The following is a description of a gene set: species: Mus musculus from publication Mikkelsen TS, Hanna J, Zhang X, Ku M, Wernig M, Schorderet P, Bernstein BE, Jaenisch R, Lander ES, Meissner A (PMID 18509334) Somatic cells can be reprogrammed to a pluripotent state through the ectopic expression of defined transcription factors. Understanding the mechanism and kinetics of this transformation may shed light on the nature of developmental potency and suggest strategies with improved efficiency or safety. Here we report an integrative genomic analysis of reprogramming of mouse fibroblasts and B lymphocytes. Lineage-committed cells show a complex response to the ectopic expression involving induction of genes downstream of individual reprogramming factors. Fully reprogrammed cells show gene expression and epigenetic states that are highly similar to embryonic stem cells. In contrast, stable partially reprogrammed cell lines show reactivation of a distinctive subset of stem-cell-related genes, incomplete repression of lineage-specifying transcription factors, and DNA hypermethylation at pluripotency-related loci. These observations suggest that some cells may become trapped in partially reprogrammed states owing to incomplete repression of transcription factors, and that DNA de-methylation is an inefficient step in the transition to pluripotency. We demonstrate that RNA inhibition of transcription factors can facilitate reprogramming, and that treatment with DNA methyltransferase inhibitors can improve the overall efficiency of the reprogramming process. Human Gene Set: MIKKELSEN_IPS_LCP_WITH_H3K27ME3 Genes with low-CpG-density promoters (LCP) bearing the tri-methylation mark at H3K27 (H3K27me3) in MCV8.1 cells (induced pluripotent cells, iPS)., and this is the list of marker genes: WFIKKN2, CORO6, CACNA1S (NCBI Gene Id 779), GAL3ST4, UGT1A1, ITLN1, PRND (NCBI Gene Id 23627), SLC23A3, MYLK2, CD244